Given this list of marker genes CBFB, EEF1E1, N6AMT1, DHX30, LAIR2, FOLR2, SUZ12, CNPY2, LTA4H, SMARCA4, MRPL34, ADK (NCBI Gene Id 132), RPF1, RPN1, SLC39A8, APBB2, PEA15, METTL3, APOLD1, METTL1, NDUFAF3, TRIM14, TST, PDSS1, DYRK4, MINPP1, LBHD1, CEP76, XBP1, VCP, DNMT1, ASF1B, KLRA1P, ATP9A, GRSF1, BARD1, CTSH, PRPF19, CAND1, KDELR2, RPS5, LSM6, LSM4, CTNNA2, MRTO4, PRDX1, TPD52, RNASEH2A, PSG7, ABCB6, DPH2, GFI1, SMC1A, GOLGA8A, MDH1, TMEM109, SEPTIN8, NME1, CCT4, SQOR, DDX50, NFYB, DPP6 (NCBI Gene Id 653748), ITIH1, APOBEC3B, PWP1, PARN, RAD23A, DDRGK1, ATP5F1B, RANGAP1, EED, PA2G4, LDHB, UQCRH (ubiquinol-cytochrome c reductase hinge protein), SNRNP25, PLEKHO1, SEPTIN6, CZIB, KNTC1, TOMM40 (translocase of outer mitochondrial membrane 40), NDUFA9, NEIL3, ATP5PF, MANF, CBR1, CHMP6, PUS7, IFI35, TOMM70, PDGFRA, RACK1, ANO10, GINS2, SPAG5, SNRNP27, IPPK, PLOD2, NHP2, DNAJC10, UBA2, AGPAT5, NUDC, PSMB8, MRPL17, PSMB2, MYH10, RPA3, CALML4, PHYH, CCNE2, GPALPP1, DYNLT1, CCT2, ERI2, AAGAB, CABYR, MFHAS1, RAN, UBXN8, ERGIC2, GSTT1, IFI16, ELOVL6, PTTG1, TUBB, POLD3, DAP3, CEP72, UBE2V2, CD28, OLA1, METRN, GSTP1, SLC26A6, MDFIC, SCD, MTX2, DPAGT1, BAD, ASNS, BIRC5, PHB1, PNP, SMS, ACOT7, FN3KRP, HGH1, NDUFAB1, VANGL1, IDH3B, KIF20B, MRPL39, ATP2A2, IFT140, UBE2M, ERCC2, MRPL24, MRPL4, REEP5, DHX57, OTUB2, NUP37, ZNHIT6, SLC31A1, GATD3, PFAS, FOXM1, EPB41L2, COPS6, APOL1, MALT1, MTX1, EIF3I (eukaryotic translation initiation factor 3 subunit I), CSTPP1, TUBB3, ZFYVE21, ENO1, TTC27, CD1C, SHMT2, MACIR, DNAJA3, HBEGF, ZNF706, BTBD1 (NCBI Gene Id 55029), IRF4, ATP8B4, LRPPRC, TYMS, MRPS33, RPS27L, HCG9, CCL4, MRE11, RUVBL1, MFSD13A, CENPU, HSPA8, FXR1, here is a description of the gene set: Human Gene Set: GSE3982_EOSINOPHIL_VS_TH1_DN species: Homo sapiens from publication Jeffrey KL, Brummer T, Rolph MS, Liu SM, Callejas NA, Grumont RJ, Gillieron C, Mackay F, Grey S, Camps M, Rommel C, Gerondakis SD, Mackay CR (PMID 16474395) Genes down-regulated in comparison of eosinophils versus Th1 cells. In the present study we used Affymetrix oligonucleotide microarrays to produce gene transcription profiles for the major leukocyte types in humans. This comprehensive dataset enabled us to not only establish which genes were expressed in each leukocyte type, but also which genes were expressed in each subset after activation. The used of a comprehensive dataset of gene profiles from all the major human leukocyte subsets enabled a novel and powerful means for identification of genes associated with single leukocyte subsets, or different immune paradigms.